Given this list of marker genes B3GALT1, B3GALT2, GALC, GBA3, UGT8, FA2H (fatty acid 2-hydroxylase), B4GALT3, PNLIPRP2, GAL3ST1, here is a description of the gene set: species: Homo sapiens Human Gene Set: GOBP_GALACTOLIPID_METABOLIC_PROCESS The chemical reactions and pathways involving galactolipids, any glycolipid containing one of more residues of galactose and/or N-acetylgalactosamine.